Given this list of marker genes NFIX, NRAS, RECQL, COLEC11, HRAS, EFEMP2, PEX19 (NCBI Gene Id 7835), here is a description of the gene set: Human Gene Set: HP_PROMINENCE_OF_THE_PREMAXILLA studied in species Homo sapiens Prominent positioning of the premaxilla in relation to the rest of the maxilla, the facial skeleton, or mandible. Not necessarily caused by an increase in size (hypertrophy of) the premaxilla. Prominence of the premaxilla